The following is a description of a gene set: Mouse Gene Set: GOBP_ESTABLISHMENT_OF_ORGANELLE_LOCALIZATION The directed movement of an organelle to a specific location. studied in species Mus musculus, and this is the list of marker genes: Cep19, Rab17, Unc13b, Pdcd6ip, Llgl2, Nefh, Dock7, Khdc3, Rrs1, Knl1, Clasp1, Myh9 (myosin, heavy polypeptide 9, non-muscle), Pclo, Myo1c, Cdk5rap2, Ms4a2, Riok2, Mapt, Mad1l1, Cep83, Cd300a, Tacc2, Wasl, Rab3a, Eml4, Dctn1, Vps4b, Gpr143, Kif1a, Trappc3, Zfp207, Lmna, Seh1l, Hdac6, Fnbp1l, Mapk8, Ripor1, Ap1s2, Kif1c, Tacc1, Hdac3, Nop9, Scrib, Ctnnb1, Tuba1a, Lin7c, Uchl1 (ubiquitin carboxy-terminal hydrolase L1), Vamp8, Borcs5, Bicdl1, Hsbp1, Sdc4, Hhex, Spg11, Pibf1, Itga4 (NCBI Gene Id 16401), Ap1ar, Chmp1b, Mylk2, Ptgds, Pard3b, Ahi1, Cdca5, Tacc3, Nsfl1c, Mei1, Kif2c, Fyco1, Cops5, Bloc1s2, Klhl12, Kif5a (kinesin family member 5A), Grp, Dlg1, Mad2l1, Lin7b, Armcx3, Cul3, Atp13a2, Kifc5b, Birc5, Baiap3, Fgf10, Unc13a, Sun2, Ubb (ubiquitin B), Kif5c, Nek2, Ccdc186, Rcc2, Mgarp, Ntn1 (netrin 1), Cfl1, Spdl1, Becn1, Actn4, Ndc80, Ankfn1, Cd84, Tex14, Snx4, Exoc6, Chmp1a, Bub3, Gja1, Dnm1, Bicd1, Chmp7, Chmp4b, Wasf1, Spc25, Aurkb, Map2k1, Nuf2, Fes, Stard3, Apc, Snhg15, Arhgef2, Prkn, Picalm, Ndel1, a, Misp, Clmn, Nlrp4f, Nppc, Kash5, Dync1h1, Abraxas2, Actr10, Tcirg1, Trappc13, Clnk, Sybu, Myo5c, Terf1, Llgl1, Lsg1, Itgb1, Trappc2, Syk, Cdca8, Chmp1b2, Crocc, Stk11, Spry2, Rab11a, Tmed9, Spry1, Nudc, Copg2, Cdt1, Chmp6, Fcer1a, Wipi1, Agtpbp1, Dtnbp1, Rasl2-9, Epcip, Myo5a, Ska3, Kif16b (NCBI Gene Id 99070), Pax6, Syt10, Kxd1, Tbc1d23, Unc13d, Exoc3, Psrc1, Ap3d1 (adaptor-related protein complex 3, delta 1 subunit), Arf1, Rabgef1, Fam91a1, Tspan9, Bicd2, Bloc1s4, Foxf1 (NCBI Gene Id 15227), Nmd3, Hif1a (hypoxia inducible factor 1, alpha subunit), Btbd8, Cdc42bpa, Stard3nl, Chmp2b, Hmox1, Dnm1l, Rab44, Il13, Nppa, Trappc1, Cenpq, Npm1, Chmp2a, Cenpf, Mark1, Bloc1s1, Mis12, Ska2, Stk25, Exoc5, Zw10, Pafah1b1, Spire1, Preb, Map1b, Rbm10, Lrrk2, Ltv1, Mapk15, Unc13c, Ap3s2, Fcer1g, Ect2, Gata2, Rab7, Gpr15lg, Zbed3, Eif6, Ptk2, Kif5b, Cep63, Stam, Lin7a, Kif18a, Arhgap33os, Pkhd1, Hgs, Trappc12, Myh10, Cdh3, Pdzd11 (PDZ domain containing 11), Exoc1, Copg1, Gem, Champ1, Map4k2, Ran, Lmnb2, Spast, Ap3m2, Mreg, Wdr11, Mx2, Nherf1, Nsl1, Il4ra, Zwint, Ywhaz, Nefl, Hook3, Pcm1, Hnrnpu, Nusap1, Dipk2a, Sirt2, Gpsm1 (NCBI Gene Id 99317), Shroom2, Meioc, Pinx1, Kat5, Cplx2, Knstrn, Fam83d, Pex14, Myo7a, Ighe, Kif28, Kif1b, Pdcd6, Ube2b, Nlrp5, Spire2, Bloc1s6, Trappc10 (NCBI Gene Id 380642), Sun1, Terb1, Synj1, Terb2, Smpd3, Stxbp3 (syntaxin binding protein 3), Ankrd53, Kat2b, Rb1, Gab2, Sgo1, Btk, Adora3, Numa1, Eml3, Pard3, Eipr1, Bccip, Dynlt1b (dynein light chain Tctex-type 1B), Exoc6b, 1700009N14Rik, Chmp3, Clasp2, Dnm2, Mlh1, Kifbp (kinesin family binding protein), P2rx7 (purinergic receptor P2X, ligand-gated ion channel, 7), Stxbp1, Kif22, Rad21l, Chmp5 (NCBI Gene Id 76959), Myo19, Cdk1, Htt, Tanc2, Bicdl2, Trak2, Fez1, Slc2a4, Ezr, Bloc1s5, Il4, Slit1, Pla2g3, Trappc4, Spice1, Myrip, Mcph1, Scn11a, Snap23, Ykt6, Spo11, Gbf1, Syne3, Rims1, Bloc1s3, Vps4a, Ap3b2, F8a, Map2, Abraxas1, Rhot2, Exoc4, Fgfr2, Rhot1, Pld2, Chp1, Naglu, Syne2 (spectrin repeat containing, nuclear envelope 2), Sapcd2, Cadps, Cenpc1, Pdcd10, Arfgap3, Arhgap21, Tor1a, Dsn1, Agbl4, Crhr1, Tle6, Ccnb1, Borcs6, Spc24, Dync1i1, Exoc8, Gata1, Pkd1, Trim58, Ap3s1, Tmed10-ps, Trappc9, Map6, Snf8, Kpnb1, Trappc11, Gpsm2 (NCBI Gene Id 76123), Fmn2, Ikbkg, Fbxw11, Syne1, Brca2, Nr4a3, 5730455P16Rik (NCBI Gene Id 70591), Borcs8, Snapin, Sar1b, Sirt1, Lat, Spag5, Arfgap2, Pmf1, Cenpa, Nup62, Tmem201, Kif2b, Syt4, Sphk2, Tsc1, Rac2, Map4, Inppl1, Rps15, Xpo1, Cep120, Tmed10, Cdc23, Dpysl2, Trim46, Snca (synuclein, alpha), Cnih2, Myo5b, Enkd1, Fgr, Cdc42, Sec16a, Dctn2, Cadps2, Trip11, Pef1, Trappc5, Borcs7, Stxbp2, Kit, Lyn, Mrgprb1, Syt11, Ccdc66, Ubxn2b, Pdpk1, Nlgn1, D6Wsu163e, Nde1, Syt6, Tspan4, Mapre1, Rab1a, Kif13a, Septin1, Atm, Incenp, Rab3gap1, Limk2, Ska1, Kif14, Majin, Madd, Exoc7, Racgap1, Cln3, Exoc2, Ap3b1, Mos, Ttk, Steap3, Nup88, Map1s, Kifc1, Mecp2, Tesk1, Ttl, Slc18a2, Atp9a, Trappc6b, Psen1, Mdn1, Cenpe, Nectin2, Ptgdr, Fhod1, Tac4, Trappc2l, Sdc1, Lat2, Dynll1, Lamp1, Rab11b, Mrgprx2, Cbl, Milr1, Rasgrp1, Plk1, Chmp4c, Hap1 (huntingtin-associated protein 1), Trak1, Spdya, Snap25, Sar1a, Il13ra2, Kifc2, Prkcz, Adora2b (adenosine A2b receptor, NCBI Gene Id 632506), Trappc6a, Tmem230, Rab27a, Sdcbp, Tsg101, Ccnb1-ps, Ap3m1, Ppfia2, Lmnb1, Chga, Dnm3, Sdad1, Cdk5, Ooep